The following is a description of a gene set: Human Gene Set: GNF2_ST13 studied in species Homo sapiens Neighborhood of ST13 suppression of tumorigenicity 13 (colon carcinoma) (Hsp70 interacting protein) in the GNF2 expression compendium Neighborhood of ST13, and this is the list of marker genes: RPS24, RPL36A, EIF3L, SRSF3, RPS7, RBMX, RPL6, RPS4X, NOL7, FBL, RPL5, EIF3D, BRD8, RPL7A, RPSA, RPL22, PWP1, RPL4, RACK1, RPL24, RPL7, RPS13, SNRPD3, RPS17, RPS23, EIF3E, RPL35A, NACA, RPL23, RPL27, SNRPD2, NPM1, BTF3, ST13, RPS3A, RPL9, RTRAF, RPL15, EEF1B2, RPL37, UXT, HNRNPA1, CNOT7, NSA2, RPS3, RPS20, EEF1G, RPL10A (ribosomal protein L10a), DDX50, RPL38, RPL17, SNRPE (NCBI Gene Id 6635), RPL31, EIF4B, LSM7, RPL19, RPL8, RPS12, RPL14, RPS6, EIF3H, RPL32, RPL3, RPL12